The following is a description of a gene set: Genes containing one or more binding sites for (ZSCAN26) in their promoter regions (TSS -1000,+100 bp) as identified by GTRD version 20.06 ChIP-seq harmonization. studied in species Homo sapiens Human Gene Set: ZSCAN26_TARGET_GENES from publication Yevshin I, Sharipov R, Kolmykov S, Kondrakhin Y, Kolpakov F (PMID 30445619), and this is the list of marker genes: RAB1A, INPPL1, LYPD1, RUVBL1, CITED1